Given this list of marker genes EIF3K, DERL1, EEFSEC, TTC5 (NCBI Gene Id 91875), TIFAB, ABCF1, SND1, PPP1CA, PRPF31, LONRF2, PIM1, SRP68, IMPACT, PRMT7, NMD3, MTRES1, DHX9, DERL2, FXR1, NOMO1, EIF4H, NOPCHAP1, GEMIN4, CPEB3, ZNF593, CPSF6, NCLN, MTIF2, STRAP, NOMO2, CINP, UNG, RACK1, SERBP1, ETF1, PQBP1, LETMD1, RPLP1, CSDE1, EIF4A3, ZNF598, SNRPN, SRPRA (NCBI Gene Id 94501), NAA16, CKAP5, TMCO1, MRRF, RBM3 (RNA binding motif protein 3), NME1, EIF3C, PES1, GEMIN5, PITX2, LEMD3, LARP1, RNF135, GUF1, ZNF622, WDR12, TMA16, EIF2S1, EIF6, DDX5, PHF6, DHX29, ERI1 (exoribonuclease 1), G3BP1, DNAJC2, IFRD2, BAG6, CPEB1, SBDS, PPIH, DDX3X, CD2BP2, FMR1, SNRPB, MIURF, SRP9, ABCE1, LETM1, SECISBP2L, SNRNP70, UHMK1, PYM1, CBX5, DAP, RNASEL, SHFL, MPV17L2, SRP54, NOMO3, LTN1, MDM2, DAPL1, UNK, YTHDF1, SLFN14, SEC61B, DERL3, MALSU1, RHBDD2, RBM39, SEC61A1, USP16, RICTOR, ITCH, NAA15 (N-alpha-acetyltransferase 15, NatA auxiliary subunit), EIF4B, SEC61A2, MCTS1, GTPBP4, MTRFR, BOP1 (BOP1 ribosomal biogenesis factor), MTOR, PRPF6, NVL, SNRPA, CPEB2, IGHMBP2, SRP72, SEC61G, PTCD3, XPO5, TMEM147, UQCC5, RPSA, CPEB4, C1QBP (complement C1q binding protein), ANG, NEMF, SMG6, EIF1 (eukaryotic translation initiation factor 1), EEF2, ZC3H12A, ERAL1, OLA1, RBM23, SNRPD1, MTIF3, EZH2, TIMM50, TOP2B, IFIH1, TMEM223, UCHL1 (NCBI Gene Id 7345), OXA1L, YBX3, PRMT5, EIF5A, MAIP1, EIF1B, METTL17, SECISBP2, SLFN12, EFL1, AFG2B, HNRNPU (NCBI Gene Id 3192), DHX33, CCDC47, EIF2A, TACO1, LETM2, YTHDF3, GTPBP6, HABP4, AFG2A, EIF5A2, NDUFAB1, EIF5AL1, NAA10, PELO, NPM1, NEAT1, HSPA5, SRP19, MAP3K20, STAU2, here is a description of the gene set: Human Gene Set: GOMF_RIBONUCLEOPROTEIN_COMPLEX_BINDING species: Homo sapiens Binding to a complex of RNA and protein.